The following is a description of a gene set: studied in species Homo sapiens Human Gene Set: GOBP_POSITIVE_REGULATION_OF_PROTEIN_AUTOPHOSPHORYLATION Any process that activates or increases the frequency, rate or extent of the phosphorylation by a protein of one or more of its own residues., and this is the list of marker genes: NEK10, PDGFB, RASSF2, TOM1L1, RAP2A, NRG1, PDGFA, VEGFA